The following is a description of a gene set: species: Homo sapiens The variability in the prognosis of individuals with hepatocellular carcinoma (HCC) suggests that HCC may comprise several distinct biological phenotypes. These phenotypes may result from activation of different oncogenic pathways during tumorigenesis and/or from a different cell of origin. Here we address whether the transcriptional characteristics of HCC can provide insight into the cellular origin of the tumor. We integrated gene expression data from rat fetal hepatoblasts and adult hepatocytes with HCC from human and mouse models. Individuals with HCC who shared a gene expression pattern with fetal hepatoblasts had a poor prognosis. The gene expression program that distinguished this subtype from other types of HCC included markers of hepatic oval cells, suggesting that HCC of this subtype may arise from hepatic progenitor cells. Analyses of gene networks showed that activation of AP-1 transcription factors in this newly identified HCC subtype might have key roles in tumor development. Fig.5, Supplementary Fig.Genes overexpressed in human hepatocellular carcinoma with hepatoblast property Human Gene Set: LEE_LIVER_CANCER_HEPATOBLAST from publication Lee JS, Heo J, Libbrecht L, Chu IS, Kaposi-Novak P, Calvisi DF, Mikaelyan A, Roberts LR, Demetris AJ, Sun Z, Nevens F, Roskams T, Thorgeirsson SS (PMID 16532004), and this is the list of marker genes: IL6, TNC, F3, NR4A1, CCND2, MMP1, TIMP1, EZR, CD44, FOS, PLAUR, KRT7, KRT19, VIM (NCBI Gene Id 7431), LAMA3, PTGS2